Given this list of marker genes Bmp4, Smad2, Twist1, Hey1, Eln, Gata3, Sox9, Nos3, Notch1, Emilin1, Rb1, Tgfbr2, Adamts5, Nfatc1, Dll4, Axin2, Efna1, Adamts19, Slit3, Tbx20, Robo1, Tgfb1, Gata4, Slit2, Robo2, Tie1, Smad6, Rhoa, Gata5, Hey2, here is a description of the gene set: species: Mus musculus The process in which the structure of the aortic valve is generated and organized. Mouse Gene Set: GOBP_AORTIC_VALVE_MORPHOGENESIS